The following is a description of a gene set: Mouse Gene Set: GOBP_GROWTH_HORMONE_SECRETION studied in species Mus musculus The regulated release of growth hormone from secretory granules into the blood., and this is the list of marker genes: Sirt1, Ghrl, Drd2, Ghsr, Adcyap1, Cdk16, Arhgef7, Itsn1, Ghrhr, Selenot, Oga, Cacna1c, Hmga2, Kiss1, Rab1a, Ghrh, Gabbr1, Kalrn, Serp1, Chd7, Ptpn11, Madd